The following is a description of a gene set: Mouse Gene Set: GOBP_POSITIVE_REGULATION_BY_HOST_OF_VIRAL_TRANSCRIPTION Any process in which a host organism activates or increases the frequency, rate or extent of viral transcription, the synthesis of either RNA on a template of DNA or DNA on a template of RNA. studied in species Mus musculus, and this is the list of marker genes: Tfap4, Smarcb1, Jun (jun proto-oncogene), Ep300, Smarca4, Taf11, Sp1, Rrp1b, Snw1, Chd1, Ctdp1, Lef1, Nucks1 (nuclear casein kinase and cyclin-dependent kinase substrate 1), Zfp639, Cdk9, Hpn, Ccnt1